Given this list of marker genes BCLAF3, LIN7A, LMO7, ZBTB6, KLF6, PAQR3, INTS6, CEBPB, ELAPOR2, ARL15, TMEM38B, MFAP3L, NRG2, SOX1, MYF5, NUDT11, PTPN12, TBX15 (T-box transcription factor 15), CDC42EP3, SMNDC1 (NCBI Gene Id 10285), BMP2, GATA3, LDLRAD4, NEK1, PRKCD, HNRNPAB, PRRC1, SP1 (Sp1 transcription factor), RAB38, SYT1, STXBP5, PF4V1, FRMD6, HIBADH, DZIP1L, SYNE2, SV2C, PLXNA2, INO80D (INO80 complex subunit D), RPRD2, AFF1, HBS1L, WNT5A, EIF5A2, FGF13, SSR3, TERB2, EREG, PTPN4, SENP7, PHACTR2, SPRY2, GBX2, FBXO4, NR4A3, FZD5, CORIN, GDF6, NEUROG2, TTC39B, RGS4, MYOZ2, RAP1A, BLTP2, VAMP2, ZNF516, CRISPLD1, PROK2, DUSP8, BACH2, MICU3, RC3H1, ATP8B2, ALCAM, PROX1, SLC35F5, DACH1, PITX2, NOTUM, MECP2, GDA, FGF18, BOLA3, NTF3, TM9SF2, ZNF81, FNIP1, RPS6KA5, GRID2, FEZ2, NEXMIF, EXOC5, UBE2H, SCN2B, KIRREL1, KLHL29, GDPD1, TMEM179B, PTPRB, WNT3, BICD2, KAT6A, GPM6A (NCBI Gene Id 2823), PRIMA1, RGS21, ZNF677, SYT16, DENND4A, HOXA3, SGPP1, GNB2, HS2ST1, LTV1, HAPLN1, EDAR, EFNB2, IFNA21, MFAP5, OLFML3, PAPSS1, AUTS2, FUT11, RP2, CDON, GTF2A1, SEMA3D, ATAD2, CCDC91, MKX, PRDM11, NCOA1, SCML1, BHLHE40, NEDD1 (NEDD1 gamma-tubulin ring complex targeting factor), DISC1, ATF7, ABCD3, HECTD1 (HECT domain E3 ubiquitin protein ligase 1), GABRA1, ZSWIM6, RORA, HORMAD2, PCLO, SLITRK1, EPHA8, RER1, KIF20A, PCDH15, SMAD6, FGFR2, CCND2, VEGFA, CAAP1, PPAT, NETO1, TMEM267, TNPO1, BLZF1, POU4F2, FRMPD4, ELOVL6, HNRNPH3, N4BP2, GHSR, NCK2, CSNK2A2, RAD51B, WNT5B, UTRN, PRDM2, MBLAC2, BICC1, RNF214, YLPM1, TOX4, ELOVL7, VPS13C, ADAM10, SLC38A3, WDR17, CSGALNACT2, PRDM1, STARD13, VSTM2A, SCAI, GABRG2, FBXO36, CCDC47, TRAPPC8, EEIG2, RBPJ, ATXN7L2, LRRN1, CCNE2, ENSA, RABGAP1L, PHRF1, CXCL5 (C-X-C motif chemokine ligand 5), SMAD2, KCTD20, SEZ6, ABHD5, SPDYE6 (NCBI Gene Id 729597), OLFML2B, PTEN, KCNV1, ZCCHC24, TMEM196, ANXA1, FGF12, GXYLT1, EXOSC8, PER3, LTN1, ZFP14, ADCYAP1, TMEM64, LIN28B, BRINP3, SYNE1, TMEM161B, MACC1, SUCNR1, ZBTB41, ZIC5, CCL28, PATE1, THSD4, ATAD5, VEGFC, TNFSF9, ALG6, MEF2D, C11orf71, MYO5C, NEMF, SMAD7, G6PC2, CRB1, RC3H2, ASCC3, DBR1, SRSF5, MCTP2, SAXO2 (stabilizer of axonemal microtubules 2), CNOT6L, PDCD1, HSPG2, TLE4, GABRA4, LNX2, POLK, LPAR1, CREB5, GTPBP10, C5orf24, FOSB, UBE2E3, BBX, TASP1, EGFL6, AFF4, NR4A2, MBNL2, PWWP3B, FBXO42, TMEM245, SNTG1, ZNF644, MTREX, PDLIM5, SDC4, CRTC2, GRK3, TTC32, TCAIM (NCBI Gene Id 285343), CXADR, TBX4, PARP8, NIP7, CLVS1, KLHL28, TIMM21, COL27A1, CCDC126, RORB, KRTAP1-5, NEGR1, C11orf87, ZNF711, SHISA6, TMEM108, FGD4, STK38L, ZNF827, DENND2C, CWC27, RSF1, FBXO43, ARAF, EPHA3, IPMK, FSTL1, PCDH10, MLX, C1GALT1C1, SYT14, IL15RA, ABCA8, HIVEP1, OR2L13, LRRC58, MTR, CERS3, TRPM6, PRKCE, POF1B, FRMD3, CLVS2, RPRD1A, NPTX2, PUM2, PPP6R1, MSX1, CILK1, PLAG1, EFNA2, HOXA11, ZBTB46, CYP4F11 (cytochrome P450 family 4 subfamily F member 11), ASB14, GPC6, ARHGAP5, SAMD8, HBP1, HOMER1, SIK3, SYP, ZDHHC5, GRAMD1B, PFDN4, SNX4, KSR2, SETD5, OSBP, CPEB3, SELE, CADM2, GRAMD1C (GRAM domain containing 1C), GUCY1A2, LCA5, UBE3A, ZER1, DSG2, PLPP3, SNX16, ATP6V1G1, SH3TC2, ACSL6 (NCBI Gene Id 56972), NIPBL, EIF2AK4, SP4, KDSR, KRAS, SLC24A2 (NCBI Gene Id 25769), MRTFA, KIAA0586, C2CD6, RBM41, PAPPA, SH3PXD2A, MEX3B, IKZF2, ZNF384, CERS6, RIMS2, NR3C1, RALGDS (NCBI Gene Id 95849), ANKRD34B, NUMB, NMT1, PID1, PRPF18, HAPSTR1, MED13, ARB2A, CLDN11 (NCBI Gene Id 5010), LATS2, DLG3, PRR16, FKBP5, NRDE2, SVIP, PPM1H, ANOS1 (anosmin 1), GNAQ, IFNA2, STRN, ZNF550, ZBTB20, DEPDC1, FAF2, KLF3, EEA1, RASSF6, PPP1R2, DNAJC11, RNF14, here is a description of the gene set: Genes predicted to be targets of miRBase v22 microRNA hsa-miR-5692b, hsa-miR-5692c in miRDB v6.0 with MirTarget v4 prediction scores > 80 (high confidence targets). from publication Chen Y, Wang X (PMID 31504780) Human Gene Set: MIR5692B_MIR5692C species: Homo sapiens